The following is a description of a gene set: species: Homo sapiens Genes in the cancer module 323. Human Gene Set: MODULE_323, and this is the list of marker genes: ZNF767P, MORF4L1, ZYG11B, DHX40, EIF2S3, JADE1, SACM1L, SLC4A1AP, JMJD1C, BEX4, ST13, SPAG9, POLR2K, TM9SF3, CWC15, MRPL20, TAF9B, ACBD3, ZRANB2, TYROBP, NEPRO, PURA, CBX3, TMED9, ZFAND3, HSD17B12, RALGDS, ACAP2, UGP2, VTA1, ORMDL1, HNRNPH3, ZZZ3, NUP133, TRO, NSF, EEF1AKMT3, SCRN1, CAB39, TTC17, MAFF, PLEKHF2, CDYL, FNDC3B, RAB1A, VMP1, ATP6V1G1 (NCBI Gene Id 9550), OSGEP, KHDRBS1, GFM1, GMEB1, H2BC11, TMEM69, LACTB, TACC1, HMGN3, AIMP1, ARID4B, TRAM1, OGA (NCBI Gene Id 23375), RBPJ